The following is a description of a gene set: part of: MITF-M-dependent gene expression This event has been computationally inferred from an event that has been demonstrated in another species.<p>The inference is based on the homology mapping from PANTHER. Briefly, reactions for which all involved PhysicalEntities (in input, output and catalyst) have a mapped orthologue/paralogue (for complexes at least 75% of components must have a mapping) are inferred to the other species. species: Mus musculus electronically inferred by orthology from the curated human pathway Reactome Pathway: Regulation of MITF-M-dependent genes involved in pigmentation, and this is the list of marker genes: Sytl2, Myrip, Mapk14